Given this list of marker genes RAB9A, PLIN3, RHOBTB3, RAB9B, CCNE1, LRRC41, HGS, HTR7, VHL, CUL3, here is a description of the gene set: studied in species Homo sapiens RHOBTB3 ATPase cycle Human Gene Set: REACTOME_RHOBTB3_ATPASE_CYCLE